Given this list of marker genes Kpna3, Wdr1, Ehmt1, Cyld, Macc1, Usp12, Patj, Ikzf2, Galk1, Tenm4, Ssr1, Lysmd3, Gabra1, Cadm1, Akr1c20, Canx, Purb, Xpo7, Ticam2, Atp23, Slc5a6, Wnk3, Zfp758 (NCBI Gene Id 224598), Fndc3a (fibronectin type III domain containing 3A), Mapk14, Cd40 (CD40 antigen), Kcnt2, Tmem72, Ctbp2, Rdh19, Nek9, Ralbp1, Prrg4, N4bp2l1, Txnl1, Mtf2, Thrb, Vps13a, Lin9, Cbll1, Fnip1, Slc25a19, Pcbp2, Btbd3, Unk, Daam1, Dpp10, Foxj3, Selenot, Rnf103, Rprd1a, Gja5, Cacna1g, here is a description of the gene set: species: Mus musculus from publication Chen Y, Wang X (PMID 31504780) Mouse Gene Set: MIR_191_3P Genes predicted to be targets of miRBase v22 microRNA mmu_miR_191_3p in miRDB v6.0 with MirTarget v4 prediction scores > 80 (high confidence targets).